Given this list of marker genes MIR30E, STUB1 (STIP1 homology and U-box containing protein 1), MIR24-1, MIR145, GRIA4, MIR20A, DMPK, SIRT5, MAPK7, SIRT1, SOD2, HAND2, MIR19B1, LTK, ATG5, LRP6, ATP2A2, NR4A3, SMAD4, FOXO1, JAK2, IL12B, PDE1A, ATF4, ADCY10, MAP2K5, CAMK2D, HEY2, BAG1, MIR28, PTPN1, PDPK1, NRG1, MIR320A, PPP1R10, MFN2, APAF1, NUPR1, MIR19A, IGF1, NKX2-5, SLC7A5, NFE2L2, SIRT4, MIR92A1, MIR34A (NCBI Gene Id 407040), COL6A1, NACA, MIR16-1, ALOX12, PPARG, LYPD3, GNGT1, MIR138-1, APOH, BMP7, RPS6KA2, SFRP2, NOL3, PDCD4, NOTCH1, MIR133A1, E2F3, ESR1, MIR106B, KIFAP3, BMPR1A, MIR140, PAX8, CAMK2A, HSF1, MAP2K4, TP53, ZC3H12A, DNMT1, MAP3K5, IFNG, BNIP3, AMBRA1, BAG3, IL12A, GATA4, MDK, MIR21, RBM10, CFLAR, TIGAR, MIR1-1, HSPB6, ENG, MYOCD, MIR195, MIR17, RGL2, CAPN2, HSP90AA1, MIR199A1, MIR210, CDKN2A, EDN1, DIPK2A, here is a description of the gene set: Human Gene Set: GOBP_MUSCLE_CELL_APOPTOTIC_PROCESS studied in species Homo sapiens A form of programmed cell death induced by external or internal signals that trigger the activity of proteolytic caspases, whose actions dismantle a muscle cell and result in its death. A muscle cell is a mature contractile cell, commonly known as a myocyte, that forms one of three kinds of muscle.